The following is a description of a gene set: studied in species Homo sapiens Human Gene Set: GOBP_NEGATIVE_REGULATION_OF_LIPOPROTEIN_PARTICLE_CLEARANCE Any process that decreases the rate, frequency, or extent of lipoprotein particle clearance. Lipoprotein particle clearance is the process in which a lipoprotein particle is removed from the blood via receptor-mediated endocytosis and its constituent parts degraded., and this is the list of marker genes: MIR133A1, LDLR, ITGB3, APOC1, APOC2, ITGAV, PCSK9, APOC3, MIR185, MIR17, MYLIP, MIR148A, MIR223, LRPAP1, ABCC8, MIR27A, MIR27B, IL19, MIR96, KHSRP, MIR128-1, CSK, MIR199A1